Given this list of marker genes Nr0b1, Adam39, Nhlh2, Gfra1, Col6a1, Wnt4, Rbmyf6, Wnt7a, Lrp6, Nppc, Tcf7, Ccdc182, Ace (NCBI Gene Id 11421), Trp63, Serpine2, Insl6, Plag1, Adam34l (a disintegrin and metallopeptidase domain 34 like), Nup107, Serpina5, Six4, Sirt1, Mmp2, Prdx4, Hoxa10, Ctnnb1, Adam34, Bmp5, Kcne1, Amhr2, Ahsg, Cyp7b1, Jmjd1c, Lsm14b, Slc22a5, Nos2, Fgf9, Plaur, C3, Wnt9b, Npr2, Igf1r, Sgpl1, Mfn2, Igf1, Serpine1, Eif2b5, Neurog1, Bik, Atn1, Bax, Sf1, Gata3, Adcyap1, Casp3, Rac1, Ren1, Nkx3-1, Bcl2l11 (NCBI Gene Id 76339), Dnajc19-ps (DnaJ heat shock protein family (Hsp40) member C19, pseudogene), 2610005L07Rik, Kitl, Bcas2, Axl (NCBI Gene Id 26362), Rxfp2, Lhcgr, Tyro3, Nudt1, Arrb1, Adam6a, Odad3, Zp3, Serpinf1, Bmp4 (bone morphogenetic protein 4), Asmt, Foxl2, Gli1, Adam6b, Vgf, Fer, Cd44, Vegfa, Rbmyf5, Rec8 (NCBI Gene Id 56739), Tbc1d20, Rab13, Acvr2a, Hyal3, Pten, Antxr2, Sod1, Rnase10, Fndc3a, Adam1b, Rxra, Gata6, Dhcr24, Cebpb, Dmrta1, Gata4, Src, Eif2b4 (eukaryotic translation initiation factor 2B, subunit 4 delta), Nup210l, Arrb2, Rbmyf7, Cyp19a1, Esr2, Oas1d, Smad4, Lhx1, Plekha1 (pleckstrin homology domain containing, family A (phosphoinositide binding specific) member 1), Akap9, Kdm5b, Msh2, Spata2, Dnaaf3, Kdm5a, Bcl2l2, Rdh10, Atm, Itih5, Psapl1, Errfi1, Adam3, Tex15, Hnrnpk, Nrip1, Stk11, Fkbp4, Ing2, Smarcc1, Adamts1, Gja1 (gap junction protein, alpha 1), Hesx1, Sohlh2, Gnrh1, Taf4 (TATA-box binding protein associated factor 4), Tnfsf10 (NCBI Gene Id 99628), Adam25, Ctsl, Hoxa9, Zfp830, Adam20, Nr2f2, Angpt1, Wt1, Adam5, Fgf10 (NCBI Gene Id 14165), Lrp2, Ppp1r9b, Arid4a, Spata22, Rad21l, Retn, Mas1, Rhobtb3, Tfpt, Ptger4, Cga, Adam26a, Tbx3, Kif18a, Ptx3, Tnc (NCBI Gene Id 21923), Scaper, Brip1, Bak1, Stat5a, Ube3a, Pgr, Myocd, Hsd17b4, Lhb (luteinizing hormone beta), Sohlh1, Eif2s2, Sycp2, Itgav, Wdr77 (WD repeat domain 77), Tsx, Idh1, Foxf2, Cftr, Nos3, Lep, Rln1, Fshr, Inhbb, Serpinb5, Brca2, Adam1a, Dmrt1, Rbmyf2, Gli2, Dmc1, Mertk (NCBI Gene Id 17289), Id4, Dhx37, Cbl, Serpinb6a, Eif2b2, Safb2, Sox8, Slit3, Tcf21, Rbmyf1, Spo11, Ptprn, Fance, Adam24, Pitx2, Kit, Star, Bcl2l1, Fgf8 (NCBI Gene Id 14179), Tex11, Hmgb2, Tesc, Mamld1, Insr, Ubb, Sfrp1, Nupr1, Sry, Pcyt1b, Apc, Wnt5a, Bmpr1b, Foxo3, Pdgfra, Tgfb2, Dhh, Kdr, Rrm1, Gdf9, Irx5, Nefh, Agt, Atrx, Schip1, Fgfr2, Zfpm2, Hoxa13, Flna, Adam29, Frs2, Ptpn11, Gm17266, Shh, Nanog (NCBI Gene Id 71950), Msh4, Cdh1, Gata1, Hnf1a, Cdkn1b, Ccno, Gas2 (NCBI Gene Id 14453), Nr5a1, Zfx, Rbmyf3, Abcb1a, Lhx9, Ybx3, Ash1l, Gdf7 (growth differentiation factor 7), Dicer1, Nipbl, Phb1, Rbp4, Hoxa11, Bmp7, Sulf1, Gpr149, Gmnc, Srd5a2, Dnaaf11, Inhba, Mcidas, Fshb, Pkd1, Psap, Eif2s3y, Rbmyf8, Rbmy, Fgf7, Foxa1, Nog, Amh (anti-Mullerian hormone, NCBI Gene Id 11705), Cited2, Bcl2, Kmt2b, Gm4787, Hnf1b, Sox2, Edn2, Ereg, Immp2l, H3f3b, Cdkn1c, Plekha5 (NCBI Gene Id 76552), Lhx8, Bok, Tex19.2, Adam18, Wnt2b, Ptch1, Adam30, Foxc1, Ar, Stra6, Nkx2-1, Asb1, Ncoa1, Sema3a, Map7, Gli3 (NCBI Gene Id 14634), Greb1l, Umodl1, Nr5a2, Spink2, Adrm1, Arid5b, Mmp19 (NCBI Gene Id 58223), Fancf, Tmf1, Mmp14, Ago4, Sox3, Tlr9, Fst, Sprr2d, Rbmyf9, Cd2ap, Chd7, Tifab, Tcf7l2, Lfng, Adam21, Ndufs6, Tex19.1, Casp2 (caspase 2), Eaf2, Icam1, Tnfaip6, Scx, Hoxb13, Ercc1, Sfrp2, Nobox, Wdr19, Adam15, Fancg, Wdr48, Patz1, Il1a, Adgrg1, Notch1, Insl3, Hoxd13, Rarg, Ccnd1, Cyp1b1, Prlr, Inha, Adam2, Ube2q1, Fem1b, Rara, Runx1, Ntrk1, Stat5b, Ctnna1, Crkl, Tlr3, A2m (NCBI Gene Id 232345), Lgr4, Osr1, Ermp1, Grk2, Bmp6, Tiparp, Pde4d, Ahr, Pla2g4a, Adam32, Klhl10, Afp, Adam4, Ror2, Adam26b, Myh9, Csmd1 (NCBI Gene Id 94109), Sox9, Fzd4, Six3, Aspm, Sdc1, Hmga2, Dlg1, Arid4b (NCBI Gene Id 94246), Dnajc19, Esr1, Fanca, Tgfbr1, here is a description of the gene set: species: Mus musculus Mouse Gene Set: GOBP_REPRODUCTIVE_SYSTEM_DEVELOPMENT The progression of the reproductive system over time from its formation to the mature structure. The reproductive system consists of the organs that function in reproduction.